Given this list of marker genes DDX3Y, PCF11, MIR519E, MIR939, RBM47, CSDC2, MIR101-1, MIR485, MIR708, EDC3, DDX19B, MIR18B (microRNA 18b), SHMT1, PCBP4, MIR199B, MIR483, NSRP1, MEX3D, MSI1, CELF4, MIR650, NANOS3, EIF4G1, RBMXL3 (NCBI Gene Id 139804), PUM2, SPEN, MIR143, CRYZ, MIR149, HNRNPC, NHP2, NCL, MIR638, HSP90AA1, MIR142 (microRNA 142), PTBP2 (NCBI Gene Id 58155), MIR26B, DDX21, ETF1, MIR10A, MIR139, EIF4A3, MIR181B1, MIR33B, MIR99A, G3BP2, PARTICL, YBX3, MIR29A, EIF4G3 (NCBI Gene Id 8672), MIR148A, SAMD4B, PTBP1, LSM14A, MIR590, MIR639, DHX36, MIR517A, LRPPRC, YTHDC1, RPS14, RBM24, MIR151A, RBM46 (NCBI Gene Id 166863), MIR187, MIR501, MIR5588, MIR96, MYEF2, LARP4B, MIR215, MIR363, MIR125B1, MIR21, MIR873, MIR211, MIR1260B, MIR214, MIR1246, PARN, MIR423, DDX25, SLPI, HNRNPA2B1, MIR1277, MIR135A1, DHX33, MIR193B, PTBP3, MIR518C, MIR99B, MIRLET7C, FUBP3 (NCBI Gene Id 8939), MIR23A, MIR27A, CPSF1, NCBP3, MIR302E, HNRNPA1, PUM3, KHDRBS1, EEFSEC, HNRNPR, AGO2, MIR374A, MIR411, HNRNPA0, CSTF3, NUDT21, MIR1224, MIR3148, MIR515-1, MIR30B, RBPMS, MIR130A, MIR24-1, ANGEL1, MIR32, DDX23, MIR125A, MIR301B, MIR196A1, ZC3H12A (zinc finger CCCH-type containing 12A), SNRNP70, MIR1181, C1QBP, PABPC1L2B, MIR30A (microRNA 30a), MIR107, LARP6, MIR659, MIR1298, MIR28, MIR3661 (microRNA 3661), MIR103B1, G3BP1, MIR655, XPO5, RPL13A, RPS7, RPS6, HNRNPA1L2, MIR10B, MIR218-1, MIR33A, MRPL12, MIR188, YTHDF3 (NCBI Gene Id 253943), NOCT, RBFOX1, CELF6, DDX17, DND1, ZNF638, MIR190B, MIR204, MIR130B, APOBEC1, PTENP1-AS, SHFL, MIR455, RARA, EIF4A1, ALYREF, MIR147A, MIR517C, MIR192, DHX9, ILF3, MIR373, ARID5A, PABPC3, MIR181C, CALR, MIR551A, METTL3, RPL35, MIR340, LSM8, MIR613, RBM15B, MIR451A, JRK, DDX39B, MIR30E, MIR505, MIR548C, CSTF2, MIR30D, MIR383, MIR132, MIR145, MIR424, MIRLET7F1, MIRLET7E, SRSF1, DHFR, MIR519A1, MIR17, NXF1, KHNYN, MIR3173, TPR, MIR892B, MIR4500, MIR302C, EIF2S2, ATXN2, MIR4516, MIR206, MIR409, DHFRP1, SYNCRIP, ZAR1L, MIR520B, MIR425, RPS5, MIR140 (microRNA 140), MIR15A, MIR874, MIR675, RBPMS2, PIWIL2, MIR202, MIR520H, DCP1A, MIR191, MIR885, HNRNPU, ESRP1, ACO1, MIR376C, PKM, MIR665, MIR133B, SNRNP35 (small nuclear ribonucleoprotein U11/U12 subunit 35), ZFP36, ZC3H12D, MIR338, MIR92B, MIR410, MIR199A1, MIR371A, ZFP36L2, MIR137, MIR4691, MIR486-1, MIR185, SCAF8, MIR608, MIR134, YTHDF2, A1CF, MIR31, MIR454, FUBP1, MIR487B, MRPS7, PABPC5, MIR330, MIR186, RPL26, ZC3H12C, MIRLET7G, EIF3D, ELAVL4, MIR384 (microRNA 384), MIR299, CSTF2T, THOC2, MIR1207, RNPS1, SNRPC, GEMIN5, MIR564, SF3B1, MIR488, HNRNPD, KHDRBS2, MIR128-1, IGF2BP1, QKI, HNRNPA3, RPL5, MECP2, CPEB3, SF1, MIR200C, HDLBP, MIR2355, PABPC1L, MIR208B, MIR148B, RBM44, MIR492, MIR200B, MIR640, MIR625, EIF4ENIF1, UPF3B, HNRNPA1L3, SUPT5H, MIR106A, MIR582, ZNF385A, MIR4286, MRPL13, KHSRP, CPEB1, CELF3, SAMD4A, MIR195, HNRNPLL, FXR1, RBM4, ADARB1, NYNRIN, RPL41, PUM1 (NCBI Gene Id 9698), MIR30C2, GRSF1, HNRNPAB, EIF3A, RC3H1, LUC7L3, SLBP, RBM42, MIR920, DAZ4, MIR301A, UTP23, GNL3 (NCBI Gene Id 26354), MIR449A, RBFOX2, MIR223, ELAVL3, MIR219A1, PEG10, PABPC1, MYH10, MIR1908, MIR222, MIR221, MIR182, HNRNPK, MIR429, MIR20B, ZCCHC13, MIR18A, CIRBP, NELFE, TIA1, TUT1, SRRM4, RBM8A, MIR193A, MIR379 (NCBI Gene Id 494328), MIR493, THOC5, MIRLET7I, GPATCH8, MIR298 (NCBI Gene Id 100126296), MIR210, MIR519B, MIR212 (NCBI Gene Id 406994), MIR562, EIF4E2, POLDIP3, DDX50, TEX13C, MIR4632, RBM5, MIR374B, MIR103A1, MIR19A, CPSF6, PIWIL1, MIR208A, MIR6086, RPS13, RBMX, MIR146A, MIR520E, DDX19A, MIR491, MIR508, SERBP1, EXOSC4, CNBP, RPS3, CELF1, ATXN2L, ANGEL2, MT-TS1, ZC3H12B, MIR346, LIN28B (NCBI Gene Id 389421), MIR127, MIR661, MIR935, MIR448, RBMXL2, NANOS1, TSN, PABPC4L, PABPC4, MIR296, MIR93, MIR552, PCBP2, ZFP36L1, MIR572, MIR224, KHDRBS3, TDRD7, MIR136, MIR758, MIR22, ELAVL2, MIR150, MIR138-1, MIR183, RBMS1, MIR548D1, RBM20, SRSF4, RBM25, CSDE1, SECISBP2, MIR4686, MIR509-1, MIR126, MIR133A1, MIR511, ESRP2, MIR29B1, MIR27B, SRSF7, LARP1, MBD2, CDC40, MSI2, NICOL1, DXO, FMR1, NANOS2, HNRNPL, SRRM3, MIR663A, LINC01783, DDX4, CARHSP1, MIR514A1, RBFOX3, MIR520D, MIR155, MIR3619, MIR769, DDX59, MIR3909, MIR506, MIR877, RBMY1A1, SRBD1, RPS2, DDX43, MIR503, LIN28A, MIR518B, CLUH (NCBI Gene Id 23277), TRA2B, MIR19B1, TEX13D, DDX41, FYTTD1, MIR654, CPEB2, ELAVL1, NUDT16, MIR302A, SF3B6, MIR34B (microRNA 34b), MIR181A2, LSM14B, FXR2, LINC02591, PPP1R8, PPIE, MIR100, EXOSC7, DPPA5, MIR203A, NCBP2, SLC4A1AP, IREB2, SNIP1, DAZ1, MIR135B, MIR365A, DDX5, ZAR1 (zygote arrest 1), UNK, ZC3H14, MIR548P, SECISBP2L, MIR26A1, RBMS3, MIRLET7B, MIR342, MIR302B, SRRM2, MIR152, MIR588, EXOSC9, PCBP1, MIR146B, TAF15, DCP1B, MIR105-1, MIR34A, TP53, DDX6, MIR205, AQR, MIR498, DAZL, DHFR2, RBM38, DDX53, MIR520C, STRAP, MIR337, MIR129-1, LINC03126, TYMS, CCT5, MIR520A, MIR329-1, CELF2, MIR20A, UPF3A, DAZAP1 (DAZ associated protein 1), DDX3X, MIR657, MIR217, MIR200A, MIR141, MIR644A, EIF4G2, IGF2BP2, RC3H2, MIR519D, TEX13A, LSM1, AUH, RPS26, NCBP1, MIR767, CPSF7, EIF2A, MIR495, HYDIN2, MIR607, STAU1, NOVA1, MIR339, MIR154, N4BP1, MIR15B, SSB, MIR362, CELF5, RSL1D1, MIR181D, PAIP2, NOVA2, MIR544A, LUC7L2, MIR543, MIR499A, DDX20, MIR335, PURB, MIR328, YTHDF1 (YTH N6-methyladenosine RNA binding protein F1), ENSG00000227733, MIR323A, MIR378A, LUC7L, MIRLET7A1, EIF4E, MIR92A1, ARC, MIR518A1 (NCBI Gene Id 574488), YBX1, MIR497, MIR98, SRSF3, RBM15, RPS3A, MIR1271, MIR361, RNF40, NUP98, MIR9-1, RPL7, STAU2, LARP4, BOLL, MIR194-1, MIR372, FUS, TEX13B, MIR526A1, RPL24, DAZ2, RBM14, MIR1-1, MIR326, RBMS2, MIR144, MIR106B, MIR490, MIR34C (microRNA 34c), MIR302D, MIR573, CAPRIN1, SUGP1, DDX39A, FECH, PABPC1L2A, IGF2BP3, MIR153-1, RIDA, COPA, CASC3 (CASC3 exon junction complex subunit), TACO1, RNF20, MIR6869, PARK7, MIR320A, MIR494, CPEB4, HNRNPM, MIR876, METTL14, MIR29C, TARDBP, LINC01145, PCBP3, MIR16-1 (microRNA 16-1), MIR25, MIR345, MIR30C1 (NCBI Gene Id 407031), EXOSC8, DAZ3, TIAL1, here is a description of the gene set: Human Gene Set: GOMF_MRNA_BINDING Binding to messenger RNA (mRNA), an intermediate molecule between DNA and protein. mRNA includes UTR and coding sequences, but does not contain introns. studied in species Homo sapiens